The following is a description of a gene set: The process in which a mitochondrial gene's sequence is converted into a mature gene product or products (proteins or RNA). This includes the production of an RNA transcript as well as any processing to produce a mature RNA product or an mRNA or circRNA (for protein-coding genes) and the translation of that mRNA or circRNA into protein. Protein maturation is included when required to form an active form of a product from an inactive precursor form. Mouse Gene Set: GOBP_MITOCHONDRIAL_GENE_EXPRESSION species: Mus musculus, and this is the list of marker genes: Fastkd2, Mrps31, Aars2, Mtg2, Mrps6, Rpusd3, Polrmt, Mrps2, Mrpl37, Mrpl58, Tfb1m (transcription factor B1, mitochondrial), Mrpl17, Gars1, Mrpl57, Mrps23, Mrps27, Trmt5, Mrpl41, Mrpl33, Mrps25, Mrpl24, Mterf1b, Mrps16, Mrpl39, Chchd1, Mrpl3, Mrpl14, Tefm, Mrpl12, Gatb, Cdk5rap1, Lars2, Mpv17l2, Mrps7, Rmnd1, Mrps26, Mrpl55, Mrps33, Rbfox2, Tufm, Fastkd3, Mrpl22, Mrpl52, Yars2, Alkbh1, Gadd45gip1, Prkaa1, Mrpl42, Foxo3 (NCBI Gene Id 97633), Mrpl21, Mrps28, Mrpl19, Sirt3, C1qbp, Fastk, Rcc1l, Tfb2m, Mrpl9, Trit1, Cfh, Aurkaip1, Mrps14, Mrpl35, Tfam, Mtg1, Ears2, Mrps15, Ptcd1 (pentatricopeptide repeat domain 1, NCBI Gene Id 71799), Mrpl53, Ptcd3, Mtrf1l, Mrps12, Mrpl2, Gfm1, Mrpl43, Mrpl44, Sars2, Mterf3, Mrpl28, Trmt10c, Mrpl1, Mrpl20, Mrpl32, Mrps18b, Mrpl40, Mettl4 (methyltransferase 4, N6-adenosine), Mrpl34, Mrpl48, Mrps34, Mrpl23, Mrpl46, Rpusd4, Tbrg4, Mrpl10, Trub2, Hars1, Kat8, Mrps24, Iars2, Lrpprc, Mrps35, Coa3, Nsun3, Twnk, Mrps30, Mrps10, Kansl3, Polr2b, Mterf1a, Hsd17b10 (hydroxysteroid (17-beta) dehydrogenase 10), Mrpl11, Mrpl38, Mtres1, Dap3, Mrps18c, Mrps9, Mto1, Trnt1, Mrpl49, Mettl8, Mrpl47, Mrpl51, Supv3l1, Shmt2, Pnpt1, Mtrf1 (mitochondrial translational release factor 1, NCBI Gene Id 211253), Mrpl50, Polr1a, Gatc, Rars2, Thap11, Ppargc1b, Taco1, Polr1b, Dars2, Fastkd1, Polr2a, Mterf2, Mrpl18, Mrps21, Mrpl27 (mitochondrial ribosomal protein L27), Kansl1, Nsun4, Qrsl1, Fastkd5, Uqcc2, Mtpap, Mrpl45, Mtif3, Wars2, Mrps17, Mrps22, Mrpl4, Angel2, Mrpl54, Ngrn, Tsfm, Elac2, Mrpl13, Prorp, Mtif2, Mrpl30, Gfm2, Polr3b, Slc25a33 (NCBI Gene Id 70556), Mrpl16, Mrpl15, Malsu1, Mrpl36, Mrps18a, Mrps5, Mterf4, Mrps11